Given this list of marker genes PDZK1IP1, FOLR1, HSD17B2, FXYD2, HLA-DRB1, NNMT, LGALS2, CD74 (NCBI Gene Id 972), LCN2, IFITM3, SERPINA1, HLA-DRB5, LYZ, TCIM, CA2, TM4SF4, CEACAM6, MMP7 (NCBI Gene Id 4316), DEFB1, DUOXA2, CLU, PIGR, SERPINA5, CRISP3, TFF2, AKR1C3, SPP1, OLFM4, GPX2, SLC4A4, CLDN10, DUOX2, TFF3, HLA-DRA, AKR1B10, GATM, TCN1, TFF1, CFTR, SERPING1, SPINK1, CRP, CEACAM7, SOD2, CD81, SLC3A1, MT1E (metallothionein 1E), C3, REG1A, APCS, here is a description of the gene set: In this study, an extensive analysis was conducted to define meta-programs (MPs) capturing intra-tumor heterogeneity across a spectrum of tumor types. The approach utilized non-negative matrix factorization (NMF) to analyze each cell type separately within individual tumor samples. This involved the analysis of malignant cells, macrophages, fibroblasts, endothelial cells, epithelial cells, T-cells, and B-cells. NMF was executed with varying parameter values (K=4, 5, 6, 7, 8, 9), thereby generating 39 programs for each cell type per sample. Each NMF program was summarized by the top genes based on NMF coefficients.\nRobust MPs were then delineated for each cell type using a set of stringent criteria, including recurrence within the same tumor, similarity to programs in other tumors, and non-redundancy within a tumor. Subsequently, these robust NMF programs were clustered (per cell type) based on Jaccard similarity, leading to the identification of MPs associated with each cell type.\nTo enhance the quality of the MPs, a refinement steps were undertaken, involving the removal of MPs suspected of reflecting low-quality data (with an overrepresentation of ribosomal proteins or mitochondrial-encoded genes), single-study inclusion, or similarity to miss-annotated cell types. from publication Gavish A, Tyler M, Greenwald AC, Hoefflin R, Simkin D, Tschernichovsky R, Galili Darnell N, Somech E, Barbolin C, Antman T, Kovarsky D, Barrett T, Gonzalez Castro LN, Halder D, Chanoch-Myers R, Laffy J, Mints M, Wider A, Tal R, Spitzer A, Hara T, Raitses-Gurevich M, Stossel C, Golan T, Tirosh A, Suvà ML, Puram SV, Tirosh I (PMID 37258682) Genes upregulated in subsets of cells of a given type within various tumors Human Gene Set: GAVISH_3CA_METAPROGRAM_EPITHELIAL_PDAC_RELATED_1 studied in species Homo sapiens